Given this list of marker genes Sgpp2, Sgms1, Sgms2, Ugcg, Kdsr, Plpp3, Gdf1, Degs1, Cers1, Degs2, Sphk1, Plpp1, Asah1, Smpd1, Sphk2, Sgpp1, Ugt8a, Cers4, Sptlc1, Cers2, Sptlc2, Cers3, Cerk, Cers6, Cers5, Sgpl1, here is a description of the gene set: species: Mus musculus Mouse Gene Set: WP_SPHINGOLIPID_METABOLISM_INTEGRATED_PATHWAY Sphingolipid metabolism (integrated pathway)